Given this list of marker genes NDUFA7, PIK3CG, ATP6V1E1, HSF2, LAMTOR5, POLR3C, BMP2, FEZ1, ANXA2, SFTPC, AASS, DLEC1, PSMG1, SPICE1, TRPV6, FAM234B, PCBP2, CEP170B, ILF2, SPI1, CREB3 (NCBI Gene Id 10488), ACAA2, CDK13, SNX13, FGL1, RDH11, S100A13, DAP3, ATP1A2, GTF2H2B, KLF7, IL4, BLOC1S1, MUC6, GAB1, STC2 (stanniocalcin 2), CNOT9 (CCR4-NOT transcription complex subunit 9), PRKAR2A, CLDN10, WIPF2, MNX1, PBX2 (PBX homeobox 2), SCG5, CDKN2C, APOD, MAGI2, RABEP1, PSMC1, NKTR, PRPH, PDE1A, CYP3A5, AMHR2, EMG1 (EMG1 N1-specific pseudouridine methyltransferase), SYCP2, RTCB, VDAC3, DNA2, IFNGR1, VSIG4, PDK4, BRCA2, MMP15, BDKRB1 (bradykinin receptor B1), CX3CL1, NTSR2, SEC31B, ITFG2, MED22, MXRA5, ACAT2, ETF1, ST3GAL6, APOBEC3B, MAP3K12, PNP, ARR3, TPP2, HOXB13, DSCAM, SH3GL1, SMPDL3B, ALK, ARPC3, ADGRL2, BLM, PHF24, IRAG2 (NCBI Gene Id 650574), COL2A1, CD300C, NTRK2, MAPK8IP1, KRIT1, CASP1, SPINK4, PRP4K, IL1RL1, FCAR, COL6A3, SLC6A7, PADI2, CAMK2G, FAH, NECAB3, HMGA1, KCNJ3, LINC01587, MFAP1, ARPC4, B3GNT2, SYT1, SUPT4H1, POU4F2, ACVRL1, CA5BP1, SGCB, PYGM, UBE2S, ZNF280B, SLC10A3, FNBP1L, BTK, MPZ, GANAB, ZNF787, GABARAP, IFNA16, CTRC, EGR3, CDC7, FPR3, ERLIN1, IL5, LMNB1, EIF4E2, CYP4A11, FAF2, RLBP1 (retinaldehyde binding protein 1), NRP1, PPM1G, GNRH2, RPL4, COX7A1, IDH1, ID4, CDH6, CUL4A, SULF1, ADAM2, MMP25, PTPRCAP, SRPX, TRAF6, DVL1, HIC2, SSR2, RUNDC3A, ASS1, SRSF3, TSPYL4, LSAMP, PATJ, RHCE, SNX29, TXNIP, MICU1, SEMA3F, PAEP, CYP4B1, TPR, S100A2, EIF4B, ACKR1, CAPN6, GABRG3, PSMB7, ST8SIA1 (ST8 alpha-N-acetyl-neuraminide alpha-2,8-sialyltransferase 1), PDLIM1, MORF4L2, SLA (Src like adaptor), OVOL3, ROS1, PKP3, LTBP2, AP3M2, CENPS, COIL, ZNF92, SIGMAR1, CACNB1, CKAP5, HECW1, CEACAM7, CCL23, CDX2, MLEC, PLCH1, SRCAP, TCEAL4, TAGLN, here is a description of the gene set: from publication Chaussabel D, Semnani RT, McDowell MA, Sacks D, Sher A, Nutman TB (PMID 12663451) studied in species Homo sapiens Human Gene Set: GSE360_HIGH_VS_LOW_DOSE_B_MALAYI_DC_DN Genes down-regulated in comparison of dendritic cells (DC) exposed to 50 worms/well B. malayi versus those exposed to 5 worms/well B. malayi. Monocyte-derived dendritic cells (DC) and macrophages (MΦ) generated in vitro from the same individual blood donors were exposed to five different pathogens, and gene expression profiles were assessed by microarray analysis. Responses to Mycobacterium tuberculosis and to phylogenetically distinct protozoan (Leishmania major, L. donovani, Toxoplasma gondii) and helminth (Brugia malayi) parasites were examined, each of which produces chronic infections in humans yet vary considerably in the nature of the immune responses they trigger.